Given this list of marker genes SCYL3, LINC00899, RNF149, FEV, ZNF862, ZNF248, CCT3, CFAP46, MAFB, CEP290, NOL8, MTFR2, PARG, FBXL14, IRF4, DDI2 (NCBI Gene Id 84301), VN1R1, SLA, OOSP2, ANGEL2, CEP85L, SLC16A4, KLF13, PRR12, WDR24, BRI3BP, CEP295, P4HA2, C15orf61, BIVM (NCBI Gene Id 54841), ZNF148, RTN4RL1, DNAAF10, AP4B1, CEBPA, DOK6, ENGASE, HHEX (NCBI Gene Id 5556), ARMC1, ERCC4, ATP11A-AS1, KIF3B, POLR3B, SLC24A4, SLC22A5, VAMP1, TASL, PHF14 (NCBI Gene Id 9678), PPME1, GLG1, PAAF1, SPAG5, CCDC66, TMEM181, TMEM132D-AS1, NUDT14, LINC00324, TSHZ3, FARSB (phenylalanyl-tRNA synthetase subunit beta), FBXO32, MSTO1, TCHP, KIF23-AS1, CCND3, GCSAM, TRIM59, FOXQ1, NEK2-DT, MRTFB, DNAL4, ARHGEF18, RNF181, CCDC18-AS1, SH3BP5L, ANKRD13D, THAP11, CALHM2, RDH13, NUDCD3, ZNF573, CNTRL, RBM26, SPOP, FAM217B, SIKE1, OSGEPL1, KLHL21, LYL1 (NCBI Gene Id 4066), THYN1, WDR5B, ASB8, TTLL10, PTCD2, CLPX, ZBTB47, FRAT2 (FRAT regulator of WNT signaling pathway 2), POLD3, ZNF581, METTL13, TAF5 (TATA-box binding protein associated factor 5), ZNF227, GID4, GALM, PLGLB2, SDHA, S100PBP, SLC38A2, RAB40C, ATG16L2, FAM111A, TTC9B, NOPCHAP1, TNFRSF1A, PPP1R3B, FBXO31, SETD2, PLP1, KLHL8, FZD2, SLC39A3 (solute carrier family 39 member 3), DCP1B, PRMT7, BBS12, TRIM23, VCPIP1, HARS2, EFL1, SOWAHC, SLC25A30, TAS2R40, CAPRIN2, RNF8, UBR2, ZNF786, NAT8B, MRPS5, FERRY3, SOCS5, KDM4B, ZNF133, GPANK1, SLC25A36, DTWD1, CCR2, ZNF680, ZDHHC8, RNASEH2B, CHCHD4, YEATS2, MYCL, ZNF292, USP48, STYXL1, COA7 (NCBI Gene Id 94485), NR2F6, ZHX3, ABHD10, FASTKD1 (FAST kinase domains 1), ADAMTS15, SH2D3C, ANGEL1, GPX8, FIRRE, EZH1, ZNF302, HSD17B1, THOC2, OTX2-AS1, SLC25A19, MYLIP, WRAP73, DUSP7, UNKL, DROSHA, ZNF589, RNF169, MRPS31, CEP44 (centrosomal protein 44), ELOA-AS1, KLF4, VESTAR, RPS2P45, KLHL24, FKBP4, ACBD4, C6orf136, CDKL3, AHSA2P, ID3, CIMAP1C, WFS1, TBC1D14, ESM1, NEURL1B (NCBI Gene Id 54492), SUGT1, here is a description of the gene set: studied in species Homo sapiens Genes up-regulated in comparison of unstimulated dendritic cells (DC) at 0 h versus DCs stimulated with R848 for 2 h. Toll like receptors (TLRs) sense microbial products and initiate adaptive immune responses by activating dendritic cells (DCs). Since pathogens may contain several agonists we asked whether different TLRs may synergize in DC activation. We report that in human and mouse DC TLR3 or TLR4 potently synergize with TLR7, TLR8 or TLR9 in the induction of selected cytokine genes. Upon synergistic stimulation, IL-12, IL-23 and Delta-4 are induced at levels 50-100 fold higher than those induced by optimal concentrations of single agonists, leading to enhanced and sustained TH1 polarizing capacity. Using microarray analysis we show that only 1.5% of the transcripts induced by single TLR agonists are synergistically regulated by combinations of TLR4 and TLR8 agonists. These results identify a combinatorial code by which DCs discriminate pathogens and provide (suggest) a rationale to design adjuvants for TH1 responses. Series_overall_design: 3 untreated, 3 treated with LPS at 2h, 3 treated with LPS at 8h, 3 treated with R848 at 2h, 3 treated with R848 at 8h, 3 treated with LPS + R848 at 2h, 3 treated with LPS + R848 at 8h from publication Napolitani G, Rinaldi A, Bertoni F, Sallusto F, Lanzavecchia A (PMID 15995707) Human Gene Set: GSE2706_UNSTIM_VS_2H_R848_DC_UP